Given this list of marker genes Ap2s1, Ap2b1, Ldlr, Apob, Ces3b, Nceh1, Ces3a, Npc2, Ap2a1, Ap2m1, Lipa, here is a description of the gene set: This event has been computationally inferred from an event that has been demonstrated in another species.<p>The inference is based on the homology mapping from PANTHER. Briefly, reactions for which all involved PhysicalEntities (in input, output and catalyst) have a mapped orthologue/paralogue (for complexes at least 75% of components must have a mapping) are inferred to the other species. Reactome Pathway: LDL clearance part of: Plasma lipoprotein clearance species: Mus musculus electronically inferred by orthology from the curated human pathway